The following is a description of a gene set: Mouse Gene Set: GOMF_ENONE_REDUCTASE_ACTIVITY Catalysis of the reaction: an enone + NADPH + H+ = a ketone + NADP+. studied in species Mus musculus, and this is the list of marker genes: Akr1c18, Akr1c6, Srd5a3, Akr1c20, Akr1cl, Srd5a2, Akr1d1, Akr1c14, Srd5a1